The following is a description of a gene set: The formation of bone or of a bony substance, or the conversion of fibrous tissue or of cartilage into bone or a bony substance, that does not require the replacement of preexisting tissues. studied in species Mus musculus Mouse Gene Set: GOBP_DIRECT_OSSIFICATION, and this is the list of marker genes: Col1a1, Git1, Fgf18, Ctsk, Mn1, Axin2, Mmp2